Given this list of marker genes Zfp281, Bcl3, Il2rb, Cpne3, Rab18, Ly6e, Zbp1, Picalm (phosphatidylinositol binding clathrin assembly protein), Rpain, Zfp36l2, Mxd1, Ankrd11, Samhd1, Stat3, Ubald2, Eif5a, Pabpc1 (NCBI Gene Id 18458), Mthfd2, Runx3, Satb1, Sema4d, Arid5b, Elovl6, Rapgef6, Larp1, Akt2, Chmp4b (charged multivesicular body protein 4B), Gzma (NCBI Gene Id 14938), Ly6a, Socs3, Trim30a, Serinc3, Ppm1h, Gpr18, Eeig1, Emb, Socs1, Serpinb1a, Trac, Sipa1l1, Ppa1, Klhl6, Sumo2 (small ubiquitin-like modifier 2), Arid5a, Crlf2, Notch1, Nfkbia, Cdkn2d, Arap2, Lamp2, Igfbp4, Fam241a, Il6st, Bcl2l11, Ncl, Txnip, Apobec3, Cars1, Rbm3, Gzmb, Kif1b, Il21r, Map3k8, Isg15, Psenen, Slc7a1, Pim1, Serpinb6b, Psme2, Cd82, Tapbp, Jund, Tpm3, Pgs1, Sell, Cebpb, Il7r, Gngt2, Tcf7, Eif1, Psma7, Grk6, Gbp2, Sbno2, Cd53, Rrp1b, Batf, Rab27a, Ablim1, Ndrg3, Pja1, Ldha, Ifngr1, Zfp36, Klrc2, Serpinb9, Gpr171, Nars1, Eif3c, Trpc4ap, Vars1, Skap2, Tsc22d3 (TSC22 domain family, member 3), Eif1a, Nup210, Myl12b, Ppp1r16b, Tspan13, Dad1, Treml2, Cd69, Cyb5a, Mrpl52, Plac8, Rras2, Btg1, Ppp1r9b, Ssbp4 (NCBI Gene Id 76900), Aars1, Zfp1, Shmt2, Smc1a, Gadd45g, Ptma, Klf13, Flot1, Ssh2, Cytip, Lsm4, Dtx3l (deltex 3-like, E3 ubiquitin ligase), Icam1, Eif2s2, Ube2d3, here is a description of the gene set: from publication Cui A, Huang T, Li S, Ma A, Pérez JL, Sander C, Keskin DB, Wu CJ, Fraenkel E, Hacohen N (PMID 38057668) species: Mus musculus Cytokines mediate cell-cell communication in the immune system and represent important therapeutic targets. A myriad of studies have highlighted their central role in immune function, yet we lack a global view of the cellular responses of each immune cell type to each cytokine. To address this gap, the authors created the Immune Dictionary, a compendium of single-cell transcriptomic profiles of more than 17 immune cell types in response to each of 86 cytokines (>1,400 cytokine-cell type combinations) in mouse lymph nodes in vivo. A cytokine-centric view of the dictionary revealed that most cytokines induce highly cell-type-specific responses. For example, the inflammatory cytokine interleukin-1β induces distinct gene programmes in almost every cell type. A cell-type-centric view of the dictionary identified more than 66 cytokine-driven cellular polarization states across immune cell types, including previously uncharacterized states such as an interleukin-18-induced polyfunctional natural killer cell state. Genes positively differentially expressed in cell type: CD8+ T cell upon treatment with cytokine: IL-1β in mouse lymph nodes in vivo. Mouse Gene Set: CUI_T_CELL_CD8_IL1B_RESPONSE_UP